Given this list of marker genes LIN7C, VGLL3, H2BC8, KIAA1549L, FAM131A, GNAI1, TULP4, ZMAT3, LSM14A, PDCD2, CDK5RAP3, TRIM24, BEX4, TACC3, MAZ, AMDHD2, AP1AR, SLC7A11, CKB, KYAT1, BRD4 (bromodomain containing 4), MCMBP, NACA4P, WDR74, EFNA4, ZEB2, VPS13A, SMC2, STK17B, LRP12 (NCBI Gene Id 80002), SMARCD1, USP46, GLCE, TCOF1, TRAPPC10, DZIP3, PDE4A, ARRB2, EPB41L1, PLCH2, GEM, NMT2, RANBP17, TOP6BL, TAF5 (TATA-box binding protein associated factor 5), SORBS2, NFIC, ZSCAN26, SF3A2, KIF14, IPP (NCBI Gene Id 3652), TMEM186, SHROOM2, SLC38A6, DOCK4, CCDC69, DCK, BAZ2B, SMOX, SRSF10, CYB5A, PIK3C2B, HIBCH, HMCES (NCBI Gene Id 56941), TGFB2, KCTD13, MIOS, MAGOHB, AP1B1, HTR2A, LRRC37A2, CDK19, BLTP3B, PAQR3, S1PR1 (NCBI Gene Id 51546), NPTXR, GSDMB, MIS12, PIK3CB, SGMS1, SCD5, PCOTH, ACAN, OR3A1, FANCI, RMND1, NBEA, CEP57, SNRPA1, PEX19, CHST2, ZNF318, RASSF2, GPER1, MMP9, SAC3D1, ADGRF5, INTS14, PHF2, PIK3R4, PORCN, WBP11, FRMD4A, TGFBR3 (transforming growth factor beta receptor 3), MS4A6A, FOSB, GPR153, NLK, DPYD, MRTFB, ART1, LRP1, POT1 (NCBI Gene Id 25913), KIT, SOS2, ZNF324, SLC4A4, RASGRP1, TNS2, YBX3, HOXA3, MACF1 (microtubule actin crosslinking factor 1), CNOT4, PITX2, MECP2, NUP133, HNF1A, ADNP2, OBSL1, MREG, RLIG1, ZNF202, MED9, AFP, PPARD, EDRF1, APOM, CCNF, RBKS, FXN, SIRT5, DNAAF2, PGAP3 (post-GPI attachment to proteins phospholipase 3), VCPKMT, TMOD1, URB1, HIKESHI, ASB13, BPGM, DNAJB5, GPC4, TRPC1, BET1L, MYBL2, NDC80, ZBTB48, BECN1, MED4, CROCCP2, RCOR3, ARNT, CTSH, STIM1, C1orf50, DDX51, PPP1R26, OLR1, GSTM4 (NCBI Gene Id 82153), PLAGL2, YTHDC2, NIP7, DHFR, TKFC, MAPK13, ZFHX3, MAGI2, AKAP1 (A-kinase anchoring protein 1), PDZRN3, TWIST1, TCTN2, CARMIL1, PCNX4, USP12 (NCBI Gene Id 219333), CTNS, MANSC1, PLEKHF2, CLCC1, PECR, TMEM53, NAA16, CLBA1, DARS2, NR2C1, GPC3, SREBF2, ZSWIM8, MRS2, here is a description of the gene set: from publication Cipolletta D, Feuerer M, Li A, Kamei N, Lee J, Shoelson SE, Benoist C, Mathis D (PMID 22722857) Genes up-regulated in CD4 T cells over-expressing FOXP3 and PPARg1 form of PPARG: untreated versus pioglitazone. studied in species Homo sapiens Human Gene Set: GSE37534_UNTREATED_VS_PIOGLITAZONE_TREATED_CD4_TCELL_PPARG1_AND_FOXP3_TRASDUCED_UP Pioglitazone treatment of CD4+FoxP3- T cells transduced with Pparg and Foxp3 up-regulated a set of genes whose products have been implicated in lipid metabolism pathways. To verify the specificity of this treatment, we performed microarray analysis on Foxp3+Pparg1-transduced CD4+FoxP3- T cells after treatment with other PPARg agonists such as Rosiglitazone (TZD) and GW1929 (non-TZD).